The following is a description of a gene set: species: Homo sapiens Any process that contributes to cytokine production by a CD4-positive, alpha-beta T cell. Human Gene Set: GOBP_CD4_POSITIVE_ALPHA_BETA_T_CELL_CYTOKINE_PRODUCTION, and this is the list of marker genes: IL6, IL1R1, IL18, ARID5A, SLAMF1, CD81, GATA3, IL1B, PRKCZ, NLRP3, RSAD2, ARG1, IFNB1, IFNA2, XCL1, DENND1B, TBX21 (T-box transcription factor 21), IL18R1, IL4